The following is a description of a gene set: studied in species Homo sapiens Human Gene Set: HP_CENTRAL_NERVOUS_SYSTEM_CYST A fluid-filled sac (cyst) located within the central nervous system. Central nervous system cyst, and this is the list of marker genes: GRIA3, BLTP1, B9D1, FTO, FARSA, BCOR, RXYLT1, NUP62, IDH1, ASXL1, B4GALT1, OCRL, PDHX, EVC2, GJB2, USP9X, MAGEL2, SOX4, TRIP13, ADNP, MKS1, CEP120 (NCBI Gene Id 153241), DPYSL5, GALNT2, PLG, ESAM, POMT2, OPHN1, TCTN1 (tectonic family member 1), ARID1B, CDC42, POMK, D2HGDH, CEP290, EXOSC3, POMGNT1, PHGDH, NPHP3, DDX3X, GFM1, ATP6V1A, IFT80, UQCC3, RPGRIP1, ABAT, CPLX1, B4GAT1, PSMD12, PEX1, WDR81, FGFR2, KRAS, DYNC2I1, EXOSC8, MUSK, CHD7, TMEM138, KIF7, PIGN, PGAP2, ODC1, CDKN1C, B3GALNT2, ESCO2, SLC18A3, FKRP, HYLS1, SMARCD1, PLAA, DHCR7, WDR73, EXOSC9, CRPPA, ALG3, ATP6V0A2, ZIC1, SLC25A46, ATP6V1E1, TMEM237, PUF60, ADAR, TSEN54, RNF113A, ERCC5, AGTPBP1, RPGRIP1L, KIF21A, GDF6, TMEM107, NRAS, GRM1, LAMA1, SMARCE1, PNPLA2, TBC1D24, SMARCC2, ARID1A, DAG1, LETM1, COL4A1, CPT2, NSD2, CSF1R, FAR1, PPP1CB, VPS35L, FLVCR2, SMG9, BPTF, KANSL1, ARMC9, KCNQ1OT1 (NCBI Gene Id 11111), GMPPB, AFF3, CTNNB1, ATP6V1B2, CCDC22, PDHA1, WASHC5, DOK7, TSEN34, MTM1, TCTN3, PLCH1, TUBGCP2, DPH2, GPC3, C2CD3, NUP54, LARS2, POLR1A, PDGFRB, BUB3, ARID2, MT-ATP6, WDR35, NONO, TMEM67, MYOD1, POMGNT2, PIEZO2, AHDC1, TMEM231, POMT1, SEMA3E, LIPT2, NUP88, TGFB2, LARGE1, TSEN15, RAPSN, FGFRL1, BUB1, SOX11, WDR26, EBP, KIF5A, HRAS, IGF2, SNX14, DYNC2H1, TMEM216, CTBP1, PMM2, DPH1, GFAP, FKTN, TSEN2, MID1, VSX1, TXNDC15, CSPP1, SMARCA4, B9D2, MAB21L1, SMARCB1, COG8, SLC35A2, TUBA1A, CEP57, TXN2, RRAGC, KIAA0586, GJB6, KCNQ1, LONP1, BUB1B, DENND5A, FBXL4, FGFR1, DOCK6, VRK1, DPF2, PDHB, ZSWIM6, TMTC3, WLS, TCTN2, DYNC2I2, SNORD118, EVC, CC2D2A, OFD1, BRAF, VPS51, POGZ, AP1S2, GLUL, TUBB, EXOC2, GPC4, GTPBP2, RNU4-2, COL3A1, SEPSECS, GLI3, POLR3A